Given this list of marker genes EMC7 (ER membrane protein complex subunit 7), SARAF, AGO3, ZC3H3, E2F3 (NCBI Gene Id 1871), COQ10B, XBP1, CDC26, PRNP, CAMLG, UFD1, ENSG00000291149, TPRA1, EXOSC4, RBM8A, GPS2, RABGAP1, DTX2, UVRAG, POLR2D, CCDC126, WBP11, MAP1S, DHX8, COPS2, ATP2B1-AS1, UBXN4, SCARF1, CTNNB1, COPB2, TMEM205, DERL2, TRIM28, C17orf49, RENBP, TMED7, GTPBP2, TMEM258, EMC2, ATG12, MOB4, TIMM17B, GABPB1, ARMT1, DNAJB6 (NCBI Gene Id 9186), BRMS1, HSPA5, TBC1D23, SMAP1, RAB1B, VPS26A, HSPA13, KHDRBS1, NPEPPSP1, ELOC, ATP6V1E1, YIPF6 (Yip1 domain family member 6), SIPA1L2, RNF13, STXBP2, MIR22HG, NAIF1, FTH1P5, HLA-A, USP22 (NCBI Gene Id 79397), C18orf32, VPS4A, CAPN7, BCL2L13, ARF4, ZNF766, CC2D1B, CCDC93, AKIRIN2, ZBTB17, GID4, COX6A1, TMEM214, GPATCH1 (G-patch domain containing 1), FBXO42, SLC36A4, MAF1, UFSP2, SPCS3, SP1, NDFIP1 (Nedd4 family interacting protein 1), MAGT1, DDX41, SUPT5H, CIAO2A, RBM23, SIRPB1, UBE2E1, TPST2, BASP1, WBP4, SELENOK, LYSET, NEU1, RAB2A, WDR20, CBX3, SETDB2, WDFY3, FBRS, ACVR1B, RAB5A (NCBI Gene Id 5868), ZFAND3, H2BC21, CLTC, GRK5, GMEB1, PRDX6, POLR1D, CD164, SPG21, NUDT21, SLC66A2, F8, SPAG5-AS1, DYM, FTH1, RBBP8, ACBD3, ZFP91 (NCBI Gene Id 80829), PRPF38A, LAMTOR5, TESK2, COX20, APPBP2 (NCBI Gene Id 10513), NDUFA1, TRIP12, DIABLO, PCNX1, RRAGA, TMEM59, CRIPT, ITPR1, VAMP7, MAPK6, BTAF1, RASA2, NPHP3, ANKHD1, CSE1L, NUP58, SAP30, CCNK, FAU, CRK, DTNBP1 (NCBI Gene Id 84062), SMU1, PPP2CB, APBA3, TRAF1, CEP170, AKIRIN1, TNFRSF14-AS1, POLR2F, TRIM69, EIF4A3, HEXB, ADPRM, CSNK2B, C1orf122, MEA1, TRIM23, GOLGB1 (NCBI Gene Id 2804), MALAT1, ZNHIT1, SNX27, ST3GAL1, ATP11B, GDI1, ATP6V1G1, MANF, MORC3, PSMF1, ZDHHC6, NDUFA2, DNAJB1, PLCXD1, FBXL13, LCOR, DERL1, INTS13, SRP54, RTN3, ATP6V0E1, MORF4L2, ARCN1, TMEM199, SPINT2, GCC1, DVL2, BCL3, TXNL1, ANP32E, GGPS1, here is a description of the gene set: from publication Schwartz JT, Bandyopadhyay S, Kobayashi SD, McCracken J, Whitney AR, Deleo FR, Allen LA (PMID 22986450) Human Gene Set: GSE37416_CTRL_VS_48H_F_TULARENSIS_LVS_NEUTROPHIL_DN We demonstrated recently that both constitutive and FAS-triggered apoptosis of human neutrophils are profoundly impaired by Francisella tularensis, but how this is achieved is largely unknown. To test the hypothesis that changes in neutrophil gene expression contribute to this phenotype, we used human oligonucleotide microarrays to identify differentially regulated genes in cells infected with F. tularensis strain LVS compared with uninfected controls. In order to examine the effect of F. tularensis on the neutrophil transcriptome, we performed microarray expression analysis on human neutrophils treated with F. tularensis subsp. holarctica live vaccine strain (LVS). species: Homo sapiens Genes down-regulated in comparison of control polymorphonuclear leukocytes (PMN) at 48 h versus PMN treated with F. tularensis vaccine at 48 h.